Given this list of marker genes MAZ, AKAP1, ARHGDIA, CLDN6, SLC45A2, F8A1, PCGF2 (polycomb group ring finger 2), ASS1, CTSD, PEBP1, TP53, CALR, BLCAP, DHX38, FGFR4, CBX4, TLN1, ZYX, CIDEB, SIRPA, IGF2, LAD1, SEPTIN9, SRRM2, here is a description of the gene set: TIP30 is a tumor suppressor whose expression is altered in human liver, prostate, lung, colon, and breast cancers. Mice lacking TIP30 spontaneously developed hepatocellular carcinomas (HCC) and other tumors at a higher incidence than wild-type mice. Somatic missense mutations in the TIP30 gene were identified in human HCC tissue specimens, which resulted in instability or abnormal cellular distribution of TIP30 protein in cells. Here, we show that TIP30 mutants are able to promote cell growth and invasion and inhibit cisplatin-induced apoptosis in the HCC cell line HepG2 negative for endogenous TIP30. Moreover, one of the TIP30 mutants can dramatically accelerate tumor formation in immunodeficient mice. Analysis of gene expression in HepG2 cells, ectopically expressing either wild-type TIP30 or mutant TIP30, by Affymetrix GeneChip array, real-time quantitative PCR, and Western blotting assays reveals that TIP30 mutants can alter expression of genes involved in the regulation of tumorigenesis. This includes up-regulation of expression of N-cadherin and c-MYC and down-regulation of expression of p53 and E-cadherin. N-cadherin knockdown with small interfering RNA in HepG2 cells expressing mutant TIP30 resulted in a profound reduction in cell viability. Taken together, our data indicate that somatic mutations in the TIP30 gene may abolish its native tumor-suppressor activity and gain oncogenic activities partially through up-regulation of N-cadherin, thereby potentiating the pathogenesis of HCC in patients. species: Homo sapiens Human Gene Set: JIANG_TIP30_TARGETS_DN Down-regulated genes in HepG2 cells (liver cancer) overexpressing an oncogenic variant of tumor suppressor TIP30 compared to its wild type form. from publication Jiang C, Pecha J, Hoshino I, Ankrapp D, Xiao H (PMID 17440068)